The following is a description of a gene set: Mouse Gene Set: GOBP_EXCITATORY_CHEMICAL_SYNAPTIC_TRANSMISSION Synaptic transmission that results in an excitatory postsynaptic potential. studied in species Mus musculus, and this is the list of marker genes: Pvalb, Pdlim4, Kcnq3, Ssh1, Shisa6, Tsc2, Cntnap2, Chrdl1, Kcnq2, Ptchd1, Gprin3, Fmr1